The following is a description of a gene set: Human Gene Set: ID1_TARGET_GENES Genes containing one or more binding sites for (ID1) in their promoter regions (TSS -1000,+100 bp) as identified by GTRD version 20.06 ChIP-seq harmonization. species: Homo sapiens from publication Yevshin I, Sharipov R, Kolmykov S, Kondrakhin Y, Kolpakov F (PMID 30445619), and this is the list of marker genes: PHF23, ZNF213-AS1, CACUL1, SRP9, SAMTOR, ANO2, RITA1, DUSP19, JPT1, NDUFA6-DT, PTPN18, INO80C, MCRS1, MPND, CETN2, ST13, EEF1A1-AS1, ARHGEF37, MPHOSPH10 (M-phase phosphoprotein 10), FRA10AC1, C6orf89, NCAPH (non-SMC condensin I complex subunit H), XPNPEP3, ARHGEF2-AS2, SNHG30, MT1G, TRAF4, F2RL1, N4BP2L2, TBC1D19, MBD4, MRNIP, UQCRFS1, SLC43A2, PRDM10-DT, SEPSECS, GABARAPL1, SLC50A1, SHPK, ADIPOR1, ACTN4, PLEKHA6, FAM91A1, KRBOX1, TBC1D9B, SYCE2, RETREG1, PGRMC2, SECISBP2 (SECIS binding protein 2), LRP1, KCTD17, SH3TC2 (NCBI Gene Id 79628), ST7-OT4, BTF3-DT, EIF1, SCN5A, GLTC1, NMNAT3, PDK1, AP1G2, DDX59, MAGI2, FOXP1, KLHL42, PRR3, TMEM60, NXT2, CATSPERD, RNF20, DNAI1, RNASEH2B-AS1, LINC02026, GATC (NCBI Gene Id 283459), THAP11, U2AF2, LINC01559, VSTM2A, FBF1 (NCBI Gene Id 85302), ANKRD63, RNU4-1, NFE2L2, PFKL, SLC18B1, OVCA2, SPACA9, STARD10, C2CD3, ENSG00000228384, CACNB2, MXI1, IFT81, DMRT2, RPSAP31, STT3B, LINC00265, CDC14B, CFAP410, CBX1, UBXN2B, COA6, RNU2-19P, SOX6, LINC02427, CNKSR1, CAPN10, TEX30, SALRNA1, ZMYND10, RNF32, RPS28, PIK3R1, NLGN1, RNF141 (ring finger protein 141), LINC00926, SEPTIN9, NDUFA7, RAPGEF3, TEFM, MRPS27, EFCAB7, MRPL13, CCDC51, EBLN3P, POLR2K, VSNL1 (visinin like 1, NCBI Gene Id 7447), AOAH, KLRG1, IFI27L1, CLIC4, MDFIC, BAG4, MCF2L, SNRPB, FBXO8, CMPK2, ADGRE2, SLC30A6, FAM219A, METTL17, RPL21P55, SH2D6, PPIL3, ADD3-AS1, H3C12, BRME1, C1orf226, CHMP4A, CSF3R, ARHGEF26, ZNF425, KCNK1, PPP2CA-DT, MEST, FGR, IFT122, PCBP3, LMNB1-DT, CCT8, PPP6R2, RGS3, RFXAP, PKP4, GZF1, SNORD25, RNF14, DRAM1 (DNA damage regulated autophagy modulator 1), DHX38, TMEM69, ARL6IP1, RPL36, NUP50, NMT2, COPB1, ZMPSTE24, PTPN2, FAHD2A, LRFN4 (NCBI Gene Id 78999), KAZALD1 (Kazal type serine peptidase inhibitor domain 1), FIRRM, GSE1, CDK4, TMTC3, RNF40, PXN-AS1, DIP2B, FANCA, WEE2-AS1, MLST8, TRABD-AS1, GANC, SYN2, BCL9, CLINT1 (NCBI Gene Id 9685), CANX, CCDC102B (NCBI Gene Id 96), CAPN1, RPS16, CHUK-DT, PAXBP1, GPR108, THAP12, TRUB2, EIF2AK1, TRIM32, CCDC127, ZNF786, COG8, AMDHD1, ADSS1, SOS2, FAM118B, ENSG00000273162, TUBA1B, CPEB2, EMSY, LYRM1, NR2F1, MTND3P6, NPM1, CCDC87, CMSS1, CKMT2-AS1, XRRA1, LHFPL2, CCS, ALDH2, ANKUB1, DAPK1, ACAD10, BLM, MAPK6, ELOVL7, DMWD, ITGA3, NPL, BHLHE40, ATP1B3, PIERCE2, ZNF460, VTI1B, ANAPC13, APEH, PIH1D1, FAN1, SLC30A6-DT, LHX5, SLC38A1, TECR, OSER1, ATXN7L1, NMT1, NMI, PTPN5, PGAP4, PNISR, HIBCH, SPATA2, SMC2, ACCS, SOX2-OT, NUP85, DAPK2, SNAPC3, DDX3X, BRIP1, ZFTRAF1, DDR1, SSBP1, UBE2CP2, WBP11, MIR942, OAZ2, CFAP68, TIAM1, TCP1, ALDH16A1, DNAJB12, HNRNPU, SYNGAP1, TPD52L1, APPBP2 (NCBI Gene Id 10513), CTNS, RGL4, PAPOLG, GRM4, ENSG00000275765, MIDN (NCBI Gene Id 94034), MBD5, GEMIN4, DHCR7-DT, ABHD10, ATP6V1E2, ATP5MC2, UBXN8, MIR616, EMC1-AS1, MIR4757, FEM1B, CNN3, FAM151B-DT, CCDC115, RAB3A, PPP3CA, ITGB1-DT, ANKRD46, MIDEAS, DCBLD2, LRRC14, TCF20, MIR337, ZW10, ACAA2, DENR, AK1 (NCBI Gene Id 203), LINC01819, CERS5, ENSG00000245008, PNRC2, INSIG2, ORAI3, TP53RK, ABHD11, CROCCP2, MOK, SPG21, ZNF689, DDX24, ZNF200, SPAG4, SCAMP3, INKA2, SLC22A23, C18orf32, CFAP96, SETD7, CCDC77, HNRNPC, FGFBP3, PYM1, RNA5SP535, OR52W1, TRIP11, SLC25A35, SP8, OXSM, B4GALNT3, AHSA1 (NCBI Gene Id 10598), TAF1B, FIS1, STAP2, ANO1, ALG1, PTMS, TPGS2, PABPC1, NUP50-DT, TASOR2, FKBP11, ERI2, GAPDH, RAB5B, CABLES1, SLC36A1, ATP6V1G1, TUBA1B-AS1, CCNH, PAM16, ICAM2, PER1, ADAP2, DHX34, KTN1-AS1, SMARCD3, LINC02313, TICRR, RTTN (rotatin), FBXO45, TMEM132A, TTC32, WNT7B, FAM151B, PDIA4, NBEAL1 (NCBI Gene Id 653928), SAMD4B, FBXL6, RPS24, HOXB-AS3, KDM2A, HYAL3, MIR3973, GPR63, CD99P1, ESRP2, LINC01416, SMARCC1, ENSG00000266313, MRNIP-DT, KCTD10, NIT1, SPATA4, DHCR7, MLEC, ITGB1, TMED3, CELP, DNAL1, ZFYVE27, HOXC-AS2, MAN2A2, ZNHIT6, ENSG00000259182, WDR12, RPN1, FBXO34-AS1, LINC00543, CTSA, MEI1, ARHGEF2, CFAP58-DT, G3BP1, ZNF410, SLC26A6, KIF22, HIVEP3, PRDM10, MICOS10-NBL1, XRCC5, TRIM31, CEP290, NSUN6, BTF3, CCDC197, CAND1, EFHB, LDLRAP1, SEC22A, ABCA17P, ILKAP, FAM135A, PPP2R3B, BCDIN3D-AS1, FDXACB1, TTF2, CEP89, IRAG1-AS1, RNU6-1122P, RNF32-DT, TP53BP1, VIPAS39 (VPS33B interacting protein, apical-basolateral polarity regulator, spe-39 homolog), GOLIM4, ITGB3BP, LONP1, REL-DT, ABCF2, TOB1, MTHFD2P6 (methylenetetrahydrofolate dehydrogenase (NADP+ dependent) 2, methenyltetrahydrofolate cyclohydrolase pseudogene 6), CDK20, WDR13, SFXN5 (sideroflexin 5), ATP5MJ, FAM107A (NCBI Gene Id 50803), SUMF2, AHCYL2, PGS1, OSBPL8, SLC8B1, JUN-DT, RSPH3, RBPJ, SCAF11, CSNK1G1, FGFR1OP2, TSN, NGRN, POMK, ZMPSTE24-DT, SLC43A1, CDKL1, M6PR, GPT2, HNRNPH1, NSDHL, ZHX2, AARSD1, GCN1, BATF2, DGKH, CTSE, MADD, ARRDC3, NR3C1, EEF1G, TRIM52, SP4, HOPX, MT1P3, MCEE, CCDC137, SLC52A3, TPR, CCDC91, MNS1, GRK6, UPP2, SOCS2, FAM47E, NOP16, ALAS1, TSPAN18-AS1, RGS2, MUC22, TREX1, NUDCD3, PTPN4, ZNF131, AKAP9, TNK1, RNU1-23P, RBM3, FUT8, GRAMD2B, EIF2AP4, LINC01635, RBM48, POU6F1, RAD1, HEATR1, PHYHD1 (NCBI Gene Id 254295), ZNF836, RPS21-DT, SKIC3, MGME1, NDUFA2, PNLIPRP1, ENSG00000201701, SIPA1L3, ZDHHC7, RPUSD4, DNAJC28, KDM1A, HSPA1A, TAPBP, ARHGAP26, ZBTB16, RBM14, COQ8A, UBR4, C11orf58, PSMD9 (NCBI Gene Id 5715), GOLGA5, NAA60, ADGRF3, MEIS3, QARS1, KCNH5, GVQW3, SLC33A1, CYFIP1, GDF9, KIAA1328, CLK3, MRRF, GHDC, C2orf15, EEF1AKMT2, BLTP2, FAM86EP, BSN, DELE1, BOC, ABCA3, LARS2 (NCBI Gene Id 23395), CDS2, ABLIM2, MIR6089, GFM1, LITAF, MYO5C, SPCS2, SNRNP200, CHTOP, MRPL4, OTUD7A, ABCB8, GSTO2, PFN2, SLC35C2, RTKN, IRF5, ZNF324, FOXP2, TRIM36, CFAP61, RPAP1, BRIX1, PHOSPHO1, LINC02374, C1QTNF1-AS1, HOXB3, OXLD1, C2CD2L, PPP1R16A, HEXIM2, THBS4, RBM39, TRIM52-AS1, RPS9, RANBP3, ARMC2, AQP2, TMEM30A, KCTD6, SELENOI (selenoprotein I), RPLP0, TM4SF5 (NCBI Gene Id 9032), POR, FBXO34, CD101-AS1, IFT70A, BSDC1, GPD2, RAI14 (retinoic acid induced 14), YWHAQ, PIP4K2B, GNS, HEATR3, PURB, CDHR3, AXDND1, LRRC1, MIS18BP1, KATNB1, THA1P (NCBI Gene Id 390816), HSPA1L (NCBI Gene Id 3305), ARPC3, PTPRU, PARL, UFC1, RBCK1, NCKAP5L, CNEP1R1, RHOC, KIF5B, LINC01948, PITX2, NIM1K, NGLY1, P3H3, COX6C, ODAD3, RPL32, MICOS10, L3MBTL2, QPCTL, DBIL5P, LINC00963 (long intergenic non-protein coding RNA 963), LINC00339, LINC00240, PEAK1, MAPK6-DT, EWSR1, GNL1, CDK13, MPZL2, AATF, TRIM71, GSAP, NUP62, PAICS, GFER, TMEM97, IVD, NDC80, EPCIP-AS1, SCRN1, PABIR1, TLN1, WDR87, BNIP1, PFDN2, ERG28, STARD7, DHX57, MECOM, VRK2, SMG9, IMP4, PHYKPL, ADK, SIN3A, CDC14A, PISD, NRXN2, ZZZ3, TIGD4, MTCO3P12 (NCBI Gene Id 107075270), RHOQ, PPP2CA, CRTC3-AS1, PSMB8, BLTP1, AMN1, ACSS2, MAU2, TMEM62, RPL37, RO60, POLK, CENPBD2P, FICD, ENSG00000241525, S100A16, SLC3A2, EML6, ATP6AP2, MTBP, PEX19, MTND4LP3, USP34, LIMK2, HRH1, ODR4, NICOL1, CDCA3, ZNF358, RN7SL62P, SEPSECS-AS1, ZNRD2, WDR47, TAF15, SH3BGRL2, ALKBH7 (alkB homolog 7), RHBDF2, DDX41, ZBTB40, LINC02372, NHP2, SNRPA1, SLC5A4-AS1, LINC03064, PJA2, ERCC1, LINC02038, MIR5695, DNMT1, FITM2, OSGIN1, TCTN1, BRAT1, BCAS3, LRP6, VWA8-AS1, C14orf119, GGA1 (golgi associated, gamma adaptin ear containing, ARF binding protein 1), TERF2, MRPL55, COX14, LGALS4, SNHG1, PGM2, H2AC5P, TBCK, DCAKD, MFSD11 (major facilitator superfamily domain containing 11), CHEK2, RNASEH2B, SLC52A2, INCENP, HEXIM1, LARP1, ACAT1, CCDC38, SRSF2, RASSF6, TTC13, GARRE1, CRIP1, PDCD10, CYSTM1, DHX8, CFAP58, FAM167A, MIR4512, SEC23A-AS1, TXNL4B, HS3ST1, SNAPC5, OSER1-DT, METTL18, FAAP24, GTPBP2, PIH1D2, HNRNPH3, RNF115, DNASE1L3, PPP4R1L, VPS39-DT, AKAP13, RN7SL149P, ANKRD10, NDST2, ATG10, CHAC1, TRIAP1, UNC13B, GPRC5C, PPP1R15B, ELAC2, CCNI, PDCD6IP, TRIP10, ENC1, CRNKL1, CERT1, PUM2, LTB4R, SNRPD2, OSBPL11, H4C5, PCCB, PPAT, SREK1, JUN, RAD23A, PEX3, MRPL39, GAU1, LSM1, PRR11, RPRD2, DUSP12, TGFBR3L, TRAF6, CREBZF, MRPL17 (mitochondrial ribosomal protein L17), RTF2, RPL37A-DT, KANSL2, EPHB2, MTF1, SERTAD2, ZNF70, CREBRF, TATDN2P3, SNORD27, TTC41P, APLP2, PLEK2, PDCL3, CSNK1A1, ASCC2, HCP5, CTDP1, MCCC2, TMEM232, MIR4662A, LNCRNA-IUR, PIK3AP1 (phosphoinositide-3-kinase adaptor protein 1), AP1M2, SESN3, DGKA, ZBED5, TSPAN31, MPI, FAM47E-STBD1, APMAP, SDHA, HERC4 (NCBI Gene Id 63907), APPBP2-DT, SACM1L, C19orf48P, MIR5197, NFRKB, RN7SL217P, BCAN-AS2, STARD9 (StAR related lipid transfer domain containing 9), RIDA, LEMD3 (NCBI Gene Id 23592), SLC30A5, SCAT1, MYLK-AS1, NADK, NFX1, MSL3, ZNF775, PLA2G6, HOXC6, CEP135, SNRPE, IL11RA (interleukin 11 receptor subunit alpha), EPM2AIP1, HNF4G (hepatocyte nuclear factor 4 gamma), ZC3H8, CTDSP2, EIF4E3, USE1, TSLP, ZIC4, ENSG00000233365, TTLL3, TPX2, SUGP1, SNX5, LSM10, PPP4R3A, RRP36, CCDC57, ENSG00000256286, NPAS1, SPTB (NCBI Gene Id 6710), POP1, AP3D1, EXOSC2, MIR3646, BMS1, SCARF2, CDK11A, GTPBP3, RAG1, PDCD6, PA2G4, PRPF40B, TRBV20-1 (T cell receptor beta variable 20-1), MBL2, FLI1, IL4I1, KIFC1, PLEKHF1, TOB1-AS1, NEU3, IL5RA, HAPSTR1, ABTB2, SENP3, UQCRQ, ANAPC7, SH3TC2-DT, ABCB9, BMP1, PAX2, LIFR-AS1, USP32 (ubiquitin specific peptidase 32), MAP1A, SERPINI1, MST1P2, OS9, SYDE2, TXLNA, NRN1L, TTC4, PMEL, MTHFR, TXNL1, LRRC17, LINC00667, TPM1, TDRD3, PARD3B, RPL37A, ZNF503, LIAT1, CDKN2D, ELP3, PDE7B-AS1, FER, PCNA, IK, ACTMAP, NAGK, RPRD1A, LINC01275, CDC123, WDR53, RPL27A, MRTFA, TOMM40, RBM18, ARHGEF26-AS1, NKAPD1, NUDT5, ABR, ATP5F1D, CEP20, CALU, FOXRED1, DUS1L, KRT8, ACADM, CENPC, PSMB9, TMUB1, ZNF217, TMA7, MCM9, DCUN1D3, DDOST, MED26, MRTFB, LMNB1, COMMD8, MCCC1, EXO1, RPS15, SNX1, MANF, TTLL5, NFATC2IP, MED18, SLC25A42, MTX3, OTP, NOLC1, SRP72, INTS6, BLOC1S2, HSCB, TIGD6, MRPS28, SEC23A, PRSS35, RAF1, ATG5, KLK10, FOSB, NRDE2, CIAO2A, METAP1D (methionyl aminopeptidase type 1D, mitochondrial), CRYZL1, NUDC, EMSY-DT, LNMICC, ATF5, VEPH1, MTA2, TSC22D1-AS1, PKN1, SERTAD3, RABL6, TXN2, MPV17L2, DNAJB1, CCDC124, DHRS4-AS1, CHERP, DPP9, LAMA1, AMOT, EXOSC4, ACVR1, TMX3 (NCBI Gene Id 54495), THOP1, ZBED5-AS1 (NCBI Gene Id 732098), INO80, CHD2, SLC25A10, ATP23, TSGA10, ZNF322, CCDC28A, C1orf50, BCL10, CLVS1, CCPG1, TLE4, DNAJC6, ENSG00000267698, ANKRD49, NR2C2 (NCBI Gene Id 7182), TMEM125, LYSMD3, ILVBL, MLH1, CASC3, ENSG00000282904, UFSP2, ALAD, OAS1, SGCA, TRPC4AP, LIMD1-AS1, TP53RK-DT, PSMD3, DDX54 (DEAD-box helicase 54), TOMM34, FBXW7, SCAPER, P3H1, ZBTB45, CLDN16 (claudin 16), ARHGAP17, MRPL44, MIR665, INF2, NDUFS8, NIP7, PKD1, CRYM (NCBI Gene Id 1428), TXNDC12, RN7SL399P, MAN2A1, MRE11, GSS, MIR3167, LONRF3, ZNRD2-DT, RNU6-312P, PDCD6-DT, UBE2D3, TSEN34, SRPRA, PMPCB, HMG20A, DLG1, RAB30, ZC3HC1, USP35, MSL2, CDKN2B, PROSER3, USP45 (ubiquitin specific peptidase 45), C12orf60, DNAJC21, MORN2, TXLNG, CDCA7L, GLIS3, USP34-DT, DAZAP1, RN7SL2, DDX1, IL16, HERC6, LINC02105, BCL10-AS1, LARS1, NQO2, INTS9, BNIP2, BCL2L13, TMEM30A-DT, CDIN1, USP8, KCNIP2-AS1, PHTF2, GCHFR, SUPT5H, ZNF503-AS2, IRF6, MROH2A, PDCD2, INTS13, MARCHF3, MSH6, TUBGCP6, UQCRFS1-DT, AFDN-DT, PCBP2, MARK2, ASH1L, ARFIP1, PWWP3A, CIAPIN1, PLAAT2, LPO (lactoperoxidase), PODNL1, OGA, RILPL2, RNU6ATAC27P, TRAPPC13, THRAP3, NCBP2, ZDHHC13, EDC4, COQ4, ATMIN, ARF3, SPNS2, ZCCHC9, ANAPC5, SUCLG2P2, GPSM3, RSBN1, SPTAN1, CISD3, ALDH1A2, NOSIP (nitric oxide synthase interacting protein), SNRPA, MGAT1, MXD1, MIR4482, ADD3, CPEB2-DT, PLEKHG6, PRKCSH, KCTD13, RFX2, TRIM11, ACKR2, H2BC3, HSDL2, RAB30-DT, SNORD26, SLC25A3, SUN1, SMG7, TNFRSF1A (NCBI Gene Id 8077), ENSG00000251942, RPS6, PSEN1, LRTM2, LINC00511, RHBDD3 (rhomboid domain containing 3), ADAT2, LMTK2, NIF3L1, POLD2 (NCBI Gene Id 5425), DPY19L4, UROD, CFAP119, F12, CENPT, LUC7L2, GANAB, MARVELD3, ACTA1, RNU5D-1, DNM2, ZNF672, ITSN1, GCKR, RNF34, BLOC1S6, CDC73, LPCAT1, CEP63, ZDHHC5, GCNT3, SALL4P5, LINC02280, GSPT1, ASCL5, SMIM15-AS1, SUCO, MIR140, CENPJ, EEF1A1, TMCC3, RABEP2, MBOAT7, SLC25A46, TRIM23, CHUK, C12orf57, HACD2, TRAPPC3, HYOU1, ELL, MRPL18 (mitochondrial ribosomal protein L18), ANXA2R-OT1, CCDC146, ALKBH6, TACC2, HEXIM2-AS1, TP53I3, ARL8A, MAN2C1, RANBP3-DT, PPP1R9A, NCBP2AS2, LZTFL1, PLEKHA7, PTPRN, TNKS1BP1, SNAP23, NR4A2, POLR3C, CCL3-AS1 (CCL3 antisense RNA 1), UBXN4, MGMT, WDR11, STX3, LRRC57, KCTD21, SNRNP70, KPNA4, PSMC3